The following is a description of a gene set: studied in species Mus musculus Mouse Gene Set: GOBP_POTASSIUM_ION_HOMEOSTASIS Any process involved in the maintenance of an internal steady state of potassium ions within an organism or cell., and this is the list of marker genes: Slc12a2, Kcnma1, Atp4a, Atp12a, Slc12a1, Scnn1b, Atp1a1, Kctd7, Slc12a4, Slc12a5, Slc12a9, Atp1a4, Atp6v1b1, Kcnq1, Atp1b2, Camk2d, Slc12a6 (NCBI Gene Id 93718), Fxyd2, Kcnj10, Kcna5, Upk3a, Atp4b, Kcnh2, Umod, Nr3c2, Atp1a3 (NCBI Gene Id 232975), Slc12a7, Wnk1, Bsnd, Atp1a2, Atp1b3, Slc12a8, Atp1b1, Slc12a3, Klhl3